The following is a description of a gene set: This event has been computationally inferred from an event that has been demonstrated in another species.<p>The inference is based on the homology mapping from PANTHER. Briefly, reactions for which all involved PhysicalEntities (in input, output and catalyst) have a mapped orthologue/paralogue (for complexes at least 75% of components must have a mapping) are inferred to the other species. Reactome Pathway: Reactions specific to the complex N-glycan synthesis pathway studied in species Mus musculus part of: N-glycan antennae elongation in the medial/trans-Golgi electronically inferred by orthology from the curated human pathway, and this is the list of marker genes: Chst8, Man2a1, Fut8, Cga